The following is a description of a gene set: This event has been computationally inferred from an event that has been demonstrated in another species.<p>The inference is based on the homology mapping from PANTHER. Briefly, reactions for which all involved PhysicalEntities (in input, output and catalyst) have a mapped orthologue/paralogue (for complexes at least 75% of components must have a mapping) are inferred to the other species. electronically inferred by orthology from the curated human pathway studied in species Mus musculus Reactome Pathway: HDACs deacetylate histones part of: Chromatin modifying enzymes, and this is the list of marker genes: Kdm1a, Arid4b, Suds3, Rbbp7, Mta1, Mta2, Sap30l, Rbbp4, Brms1 (NCBI Gene Id 107392), Mbd3, Sap30